The following is a description of a gene set: Mouse Gene Set: GOBP_MAINTENANCE_OF_ANIMAL_ORGAN_IDENTITY The process in which the identity of an animal organ is maintained. Identity is considered to be the aggregate of characteristics by which a structure is recognized. species: Mus musculus, and this is the list of marker genes: Adgrv1, Nphp3, Ush2a, Pkp2, Iqcb1